Given this list of marker genes CXCL8, NFKBIZ, RELA, DDIT3, NFKB1 (nuclear factor kappa B subunit 1), here is a description of the gene set: species: Homo sapiens Pathway Definition from KEGG: FUS-DDIT3 == (NFKBIZ+NFKB) => CXCL8 FUS-DDIT3 fusion to NFKB-mediated transcription. Pathway ID: N00140. Pathway type: Variant. Pathway class: nt06240 Transcription. Human Gene Set: KEGG_MEDICUS_VARIANT_FUS_DDIT3_FUSION_TO_NFKB_MEDIATED_TRANSCRIPTION